Given this list of marker genes SRGAP1, TUT7, NEGR1, ZBTB11, MID1, GPR137, CXCR4, UNC5D, CNTNAP3, ADM, here is a description of the gene set: Genes predicted to be targets of miRBase v22 microRNA hsa-miR-11401 in miRDB v6.0 with MirTarget v4 prediction scores > 80 (high confidence targets). studied in species Homo sapiens from publication Chen Y, Wang X (PMID 31504780) Human Gene Set: MIR11401